Given this list of marker genes TCF20, ARL10, SLC10A3, SIAH2, SRSF6, GDAP1L1, COLEC10, MMP16, ZFYVE1, NOVA1, C9orf72, ZBTB2, LANCL1, TRAF6, MAP3K8, CCL5, SLC16A14, PLSCR4, CXXC4, GPM6B, YWHAB, CPM, PPP1R11, LRRTM2, ZNF493, MED20, CTAGE8, SEC23IP, CTAGE9, ZNF540, TOR1A, UPP2, MPHOSPH6, HNRNPD, BIVM, FBXO4, CYP27B1, APPL1, BRK1, ZNF275, ABL2, DDHD1, CARD10, EIF4G2, ZNF649, MBNL3, CCK, FOXR2, DCDC1, DCAF12, RHOBTB3, CTAGE4, C3orf38, NOS1, FLNA, RARB, GATAD1, TDRKH, THAP5, LRCH1, ZNF676, VPS54 (VPS54 subunit of GARP complex), ZNF367, HIPK3, SLC38A1, CD80, CXADR, VASN, LRP2, FBXW2, USP6, SAMSN1, TMEM19, STRBP, POFUT2, IRAK1, PPBP, SRP72, NUMB, ZNF354B, CASP7, YES1, WWC2, KCNJ16, PTPRA (protein tyrosine phosphatase receptor type A), SHCBP1, BCORL1, BHLHE41, GALNT10, ZNF506, ZNF257, MED1, ZNF662, TMEM120B, FLOT2, SLC12A6 (NCBI Gene Id 9990), SORT1, AMPH, ZNF652, CD96, FZD1, ERBB4, GRIA3, ZNF136, SRD5A2, CNTF, C8orf88, MOCS2, NEMP1, USP32, ZNF90, NEB, PPM1K (NCBI Gene Id 152926), ZNF253, RPF1, MRS2, here is a description of the gene set: Human Gene Set: MIR146A_5P species: Homo sapiens from publication Chen Y, Wang X (PMID 31504780) Genes predicted to be targets of miRBase v22 microRNA hsa-miR-146a-5p in miRDB v6.0 with MirTarget v4 prediction scores > 80 (high confidence targets).